The following is a description of a gene set: Any process that activates, maintains or increases the frequency, rate or extent of cholinergic synaptic transmission, the process of communication from a neuron to another neuron across a synapse using the neurotransmitter acetylcholine. species: Homo sapiens Human Gene Set: GOBP_POSITIVE_REGULATION_OF_SYNAPTIC_TRANSMISSION_CHOLINERGIC, and this is the list of marker genes: SLC18A3, LAMA2, TACR2, NALCN, ADORA2A, TACR1, TAC1